The following is a description of a gene set: Human Gene Set: HP_HYPOPIGMENTED_SKIN_PATCHES studied in species Homo sapiens Hypopigmented skin patches, and this is the list of marker genes: CHN1, SMO, FANCB, RFWD3, TERT, COMT, RTEL1, KRT5, FAS, ANTXR1, PTEN, CTSC, FANCF, FANCA, KIAA0319L, BLM, MAD2L2, TNFRSF1B, KITLG, BRCA2, SDHB, PTPN22, FANCI, PIK3CA, FERMT1, SDHD, PAX3, TCF4, EDN3, NRAS, DKC1, EBP, PCNT (pericentrin), TBX1, ABCB6, SALL4, TYR, BRCA1, TMC6, UBE2T, TINF2, FANCM, SOX5, CIB1, HIRA, SDHC, TWIST2, ALK, CD28, KRT14, BRAF (NCBI Gene Id 673), ERCC2, NPM1, SLC6A19, FGFR2, USF3, RAD51C, XRCC2, RREB1, XPC, CCR6, CRIPT, ERCC3, ERCC5, FANCD2, TYMS, ERF (ETS2 repressor factor), AKT1, RAF1, PSAP, XPA, IL7, NOP10, CAV1, SEC24C, TERC, FGFR3, ARVCF, SEC23B, AIRE, MTOR, BTK, ERCC4, ZEB2, PALB2, TMC8, MITF, GP1BB, EDNRB, NDUFB11, SNAI2, WRAP53, COX7B, BRIP1, FANCE, DDB2, FANCG, CTC1, KLLN, USB1, FANCL, MAFB, ABCC9, HCCS, RAD51, SOX10, GALC, CTLA4, IRF5, CCN2, HLA-DRB1, IKBKG, NHP2, CLTRN, FANCC, JMJD1C, SLX4, UFD1, ACP5, UBE2A, PARN, KIT